The following is a description of a gene set: Genes predicted to be targets of miRBase v22 microRNA hsa-miR-4321 in miRDB v6.0 with MirTarget v4 prediction scores > 80 (high confidence targets). Human Gene Set: MIR4321 from publication Chen Y, Wang X (PMID 31504780) species: Homo sapiens, and this is the list of marker genes: CXCL9, STOX1, TRO, TLCD3B, ADGRL2, DYRK1A